The following is a description of a gene set: species: Homo sapiens Human Gene Set: HAY_BONE_MARROW_NK_CELLS from publication Hay SB, Ferchen K, Chetal K, Grimes HL, Salomonis N (PMID 30243574), and this is the list of marker genes: CD244, RAMP1, MIR142HG, SIRT2, KIR2DL3, G6PD, CTDSP1, CEMIP2, GSAP, UBE2F, ARHGDIB, GFOD1, ARPC4, MYL12A, IFITM1, PDZD4, USP28, LRP10, TNFRSF18, EBP, IFI16, ITGB2, TSPAN2, AKNA, SCP2, APOBEC3H, PSMB9, NMUR1, LINC00869, SLA2, TBX21, RPS19BP1, EFHD2, IFITM2, TSEN54 (NCBI Gene Id 283989), TTC38 (NCBI Gene Id 55020), MVD, ADRB2, CD320 (NCBI Gene Id 51293), LIM2, ACTN4, DIP2A, EIF3G, TRGV9, TMED2, DTX3, CIRBP, CHST2, PDIA3, ANXA6, CERS4, PIP4K2A (NCBI Gene Id 5305), TRAPPC1, TBCB, TLE1, FUT11, TMIGD2, GCHFR, ASCL2, MYBL1, ZBTB16, HLA-F, APOBEC3G, CXCR2, STX8, CALM1, CTBP2, HENMT1, BIN2 (NCBI Gene Id 51722), JAK1, AK5, SSBP4, YES1 (YES proto-oncogene 1, Src family tyrosine kinase), RNF167, EOMES, CTSW, ADAM8, BTN3A2, SLC1A7, IL18RAP, VIPR2, POLR2J3, HMOX2, TOX, MIB2, PCSK7, GNGT2, BZW1, HAVCR2, PDGFD, NCALD, MATK, LINC01138, SEPTIN7, SBK1, PTGDR, FCRL6, CYRIB, ACTR3, PRKACB, SYTL1, RBM39, APMAP, TAP1, HEXA, CCDC12, DDX6, KIR2DL4, RBM38, NFATC2, KLRF1, KLRB1, STAT4, NCR1, USB1, CPNE1, HLA-C, SLFN13, BPGM, DSTN, C1orf56, MMP25-AS1, MMP23B, SMKR1, LDB2, SELENOT, BNC2, RAB5C, STK10, CAP1, HLA-E, GRIK4, KLRC2, ID2, CORO1A, PXN, CCNJL, TAPBP, TBCC, GNG2, SKAP1, FSD1, PYROXD2, RPS6KA1, DENND2D, SH2D2A, SIGLEC7, GZMM, COMMD5, C1orf21, ZNF276, ITGB7, TRGC1, IDI1, STARD3NL, DDIT4, FGFBP2, APOL6, DHRS3, CCDC102A, TINF2, PDE6G, KRT86, GPR65, CYB561D2, POLR3GL, CCDC107, PTGER2, PSMB10, PYHIN1, RAC2, YPEL1, ABCB1, CD160, PLEKHA1, YPEL3, MED10, B2M, CD7 (NCBI Gene Id 924), MBP (NCBI Gene Id 4155), ARHGAP30, CTSC, CCL3, DHRS1, DTHD1 (NCBI Gene Id 401124), SASH3, SIGIRR, ARHGAP9, IL12RB1, TADA3, DMKN, CEP78, DDX5, TCF25, RGS9, MYOM2, PRKCH, PTPN4, KLHDC4, PTPRA, CHST12, KIR3DX1, SCLT1, CX3CR1, KLRC1, TGFBR3, MAPK1, LPCAT1, NDUFB7, SPTSSB, CFL1, CD247, DOK2, ARPC5L, ABHD17A, ARK2C, SHISA5, NHERF1, PPP2R2B, RAP1GAP2, GZMA, ZNF600, TSC22D4, CD300A, PRR5, XCL2, AUTS2, PRDX5, MYO1F, WIPF1, ZAP70, GTF3C1, FHL3, TKTL1, ARL6IP5, PAFAH2, PITPNC1, ST6GALNAC6, POLR2G, LLGL2, OSTF1, ERICH6-AS1, PRSS23, NAALADL1, PRPF38B, FASLG, MRPL10, SELENOW, MCTP2, CYB5B, RNF213 (ring finger protein 213), CLIC3, GNLY, RAB29, NKG7, MLLT6, MIEN1, RHOF, IL2RG, CLIC1, GZMB, SLC44A2, TRDC, TOX-DT, NCR3, DGKZ, SDF4, KLRD1, SYNE1, KIR2DL1, ZMAT4, CIB1, CAPN12, SYTL2, TBC1D10C, OSBPL5, PRKX, KIR3DL2, MYL12B, HOPX, HCST, SUN2, SYTL3, LAMP1, PSME1, MOB2, RNF166, TXK, SPON2, ZBP1, OPTN, TES, PRF1, SH2D1B, TFAP2E-AS1, GK5, LGALS9B, CMC1, RUNX3, LINC02384, CBLB, FBXO6, BOK, AGK, PFN1, SIDT1-AS1, MLC1, S1PR5, IGF2R, PLEKHG3, CARINH, ERBB2, ITGAL, LGALS9C, RSRP1, IER2, IRF1, COMMD7, MAFF, CDC42SE1, PLEKHF1, CDK2AP2, HLA-A (NCBI Gene Id 3105), APOBEC3C, SIPA1, LINC02084, AOAH, NDUFB2, FEZ1, PILRB, SHFL, CST7, IL2RB, PLAAT4, HSH2D, KIR3DL1, CISD3, ARPC2, HDDC2, PLAAT3, ADGRG5 (NCBI Gene Id 221188), UCP2, DHRS7, RNF126, CD53, B3GNT7, RASSF5, VPS37B, RASSF1, PPP1R18, TPST2, XCL1 (NCBI Gene Id 92337), CASP8, UBE2L6, NFATC3, MIR181A2HG, ADGRG1, SAMD3, PRR5L, ARL4C, CFLAR, CCL4, ADGRE5, GNPTAB, TSPAN32, LAIR2, LITAF, CERCAM (cerebral endothelial cell adhesion molecule), NCAM1, LINC02481